The following is a description of a gene set: Genes down-regulated in comparison of dendritic cells (DC) stimulated with Gardiquimod (TLR7 agonist) at 0.5 h versus those stimulated with Gardiquimod (TLR7 agonist) at 4 h. studied in species Homo sapiens Human Gene Set: GSE17721_0.5H_VS_4H_GARDIQUIMOD_BMDC_DN mouse primary BMDCs were stimulated with tlr ligands and gene expression changes were profiled on Affymetrix arrays from publication Amit I, Garber M, Chevrier N, Leite AP, Donner Y, Eisenhaure T, Guttman M, Grenier JK, Li W, Zuk O, Schubert LA, Birditt B, Shay T, Goren A, Zhang X, Smith Z, Deering R, McDonald RC, Cabili M, Bernstein BE, Rinn JL, Meissner A, Root DE, Hacohen N, Regev A (PMID 19729616), and this is the list of marker genes: LYN, MAPK8, LDLRAD4 (low density lipoprotein receptor class A domain containing 4), IL15RA, UBE2B, RND3, CMTR1, IFNAR1, CARMIL1, ITGAV, IKBKE, TADA1, NUS1, BMI1, PIM3, SLC25A29, VCL, MT2A, GPR85, CSF1, IFNAR2, MDFIC, RCL1, NUMB, AMFR, ACKR3, FAM53C, BRD2, NXF1, ARID5B, TOP1, ACP2, SASH1, CST7, HCCS, NCAN, VASP, PDE8A, TRPM1, TBPL1, DUSP16, ZNF189, NAMPT, SACM1L, HSD17B12, RAC1, TOR3A, NFKBIB, BTG3, ZNRF1, DACH1, BLNK, NPPC, NFKBIA (NCBI Gene Id 4792), RUFY3, CD80, MYEF2, DDHD1, DDX60, PARP8 (NCBI Gene Id 79668), IL36G, ACKR1, SLC30A7, CHRND, RARS1, EIF4A1, PI4K2B, CRYBA2, CAVIN4, DLGAP4, CLDN3, SUOX, TP63 (tumor protein p63), IRF1, RAB8A, STAC2, CD5L (CD5 molecule like), FMR1, UBXN8, FAM184B, HSP90B1, PIAS1, ALKBH3, ATF2, PLPP7, LEP, IFITM10, HECTD1, YIPF4, MAN1A2, MAP4K5, PPM1B, ME1, CAMK2D, RAP1B, PTPN11, LPAR1, WDR48, GDI1, VEGFC, ARL1, UFM1, PPP6C, CYP2F1, SNX4, SRSF11, DPP8, SNAPC3, TNFRSF1B, UBA3, FBRS, CALCRL, TNKS1BP1, IL17RA (NCBI Gene Id 23765), SLC44A1, KLF3, NR3C1, NADK, KLF6, INAVA, ATP1B1, AKT3, SUSD2, ADGRL4, POLR3D, ABR, LPP, GHRHR, ZNF565, LATS2, FSTL1, KCTD14, LTN1, RXYLT1, MFSD1, FAM114A2, PLAT, USP47, ITPR2, BIRC3, GABPA, IFIH1, SRSF10, PRPF38A, ADAM17, KPNA1, MYNN, SYNCRIP, SAV1, HVCN1, COIL, CHRD, PLEKHF2, NT5C3A, APPBP2, ARMCX3, C9orf40, PABIR1, UBE3A, ADGRF1, KIF3C, STX12, PLAUR, SLC41A1, PELI1 (NCBI Gene Id 57334), GABRB1, ADHFE1 (alcohol dehydrogenase iron containing 1), EBI3, CRK, ZFYVE16, SLCO5A1, ANTXR2, C16orf87, TM9SF4, FBXO33, RAI14, LBH, TGM2, C21orf91, SERINC1, RABGEF1, DEFB4A, ZNF260, RUSC2, MSN, ENTR1, DTWD1, NUDCD1, PDLIM7 (PDZ and LIM domain 7), TAF1B, NRG4, ATF3 (NCBI Gene Id 467), MSANTD3, SLK, RGS9, RNF11, MAN2A1, HACE1, CLTC, ARL14EP